Given this list of marker genes CRKL, GIMAP2, PFKM, ELF2, RAD51B, WDR82, UHRF1, TNPO1, INO80D, NR2C2, CREBZF, TMPRSS11A, PTPRD, USP33, LONP2, NFKBIZ, EGLN1, CAPRIN2, UNC80, VPS13C, TENT5A, TMEM182, ARL17A, PCDH15, IL23A, CENPP, TSPAN31, LEF1, TFAP2A, C2orf72, SIX1, ACP2, FKBP14, PRNP, CHST2, TPK1, PRELID2, here is a description of the gene set: Human Gene Set: MIR4301 Genes predicted to be targets of miRBase v22 microRNA hsa-miR-4301 in miRDB v6.0 with MirTarget v4 prediction scores > 80 (high confidence targets). studied in species Homo sapiens from publication Chen Y, Wang X (PMID 31504780)